The following is a description of a gene set: studied in species Homo sapiens Human Gene Set: GOBP_CILIUM_OR_FLAGELLUM_DEPENDENT_CELL_MOTILITY Cell motility due to movement of eukaryotic cilia or bacterial-type flagella or archaeal-type flagella., and this is the list of marker genes: CFAP144, PGAM4, PRSS55, CELF3, RFX3 (NCBI Gene Id 5991), IRGC, IQCG, ATP2B4, PRDM14, CATSPERZ, SPMIP8, EFCAB9 (NCBI Gene Id 651812), LDHC, TEKTL1 (NCBI Gene Id 126402), PACRG, KIF9 (kinesin family member 9), CATSPER2, CFAP119, CCDC40, SLC22A14, MAFIP, CFAP141, GARIN3, TACR2, CFAP47, LZTFL1, TUBA1A, EFCAB6, PDCL2, LRRC46, AKAP3, SPACA9, SPAG8, APOB, RSPH9, SEMG1, AKAP4, ARMC2, CCDC39, YIF1B, NEURL1, TMF1, SLC9C1, CCDC38, CFAP45, TUBB4B, CFAP251, CFAP20, CFAP221, TTLL9, SPAG6, CFAP97D1, TPPP2, RSPH4A, POC1B, DNAH5, TEKTIP1, TTC21A, SEPTIN4, CCDC65, PIERCE2, SPMIP10, GARIN2, TTLL3, SLC22A16, LRRC23, CATSPER1, CFAP54, TEKT3, TSSK6, ROPN1, ING2, CATSPER3, SLIRP, ASH1L, CFAP157, CFAP44, EFHC2, CFAP77, MKKS, TACR3, QRICH2, DNAH17, BBS4, RIBC1, CFAP57, TMEM232, EFHC1, DPCD, CFAP90, CCR6 (C-C motif chemokine receptor 6), VPS13A, KIAA0319L, CFAP52, CFAP46, DUSP21, CABS1, RNASE10, DNAH2, DRC7, CFAP126, BBOF1, DNAAF2, DNAI3, DNAH3, CFAP276, IQCF1, DRC1, DZIP1, CIMAP1A, CFAP65, SEMG2, ROPN1L, TTLL1, DNAH11, PIERCE1, SPMIP9, UBE2B, TEX101 (testis expressed 101), CEP128, PLA2G3, ATP1A4, CEP131, TEKT4, TAC3, CCDC159, TPGS1, SPMIP6, TNP1, SAXO4, GK2, TLE6 (TLE family member 6, subcortical maternal complex member), DDX4, TBC1D21, SPEM1, SPEF2, FSIP2, DNALI1, PGK2, CCNYL1, SLC9B1, EFHB, EPPIN, CFAP107, GAS8, ROPN1B, CFAP206, CATSPERD, KLC3, RIBC2, IQUB (NCBI Gene Id 154865), CFAP61 (cilia and flagella associated protein 61), TSSK4, SLC9B2, CFAP95, CFAP210, TTLL6, DNAH1, CFAP69, PLTP, DNAH9, DEFB1, ADAM7, GAS2L2, ADCY3, CFAP68, TTLL5, CFAP58, DNAAF6, ARMC12, TEKT2, TTC12, RSPH6A, PFN4, DNAH6 (dynein axonemal heavy chain 6), PRM3 (protamine 3), INTS13, SPAG16, TCTE1, SPEM3 (NCBI Gene Id 107983988), TEKT5, MNS1, SPMIP11, BBS2, ENKUR, HOATZ, MEIG1, TACR1 (NCBI Gene Id 6869), C2CD6, NME8, DYNC2H1, VDAC3, CFAP161, ZMYND12, TEKT1, CLXN, DNAH14, DNAI1, NPHP4, DNAAF11, GAPDHS, TAC4, DNAH7, IFT81, TAC1, CFAP43, CIMIP2A (NCBI Gene Id 401565), CIMIP2C, BBS1, CATSPER4, CCDC146, TTLL8, CFAP53, INPP5B, SORD, NME7, ARMC3, DNAH8, DNHD1, CEP78, SMCP, CATSPERE, DNAH10, ODAD3